Given this list of marker genes Ppara (NCBI Gene Id 399624), Nr5a1 (nuclear receptor subfamily 5, group A, member 1), Rorb, Thra, Thrb, Nr2f1, Rarb, Nr1d1, Paqr7, Or51e2 (NCBI Gene Id 70818), Nr2e3, Nr5a2, Nr1h4, Esr1, Pde3a, Vdr, Nkx3-1, Rara, Esrrb, Ahr, Nr1d2, Nr2e1, Esrra, Arnt, Rorc, Abhd2 (abhydrolase domain containing 2), Nr2c2, Hnf4a, Pgr, Nr1h5, Rora, Nr1i3 (NCBI Gene Id 98393), Ar, Nr1i2, Rxra, Nr6a1, Stat3, Esr2, Nr1h2 (NCBI Gene Id 381996), Rarg, Nr3c2, Hnf4g, Nr4a1, Esrrg, Pparg, Nr2c1, Nr2f6, Srebf1, Bach1, Nr4a2, Pou5f1, Nr1h3, Nr4a3, Paqr8, Nr2f2, Ahrr, Rxrg, Ppard, Rxrb, Gper1, Nr3c1, here is a description of the gene set: Mouse Gene Set: GOMF_LIGAND_MODULATED_TRANSCRIPTION_FACTOR_ACTIVITY studied in species Mus musculus A DNA-binding transcription factor activity regulated by binding to a ligand and that modulates the transcription of specific genes and gene sets. Examples include the lac and trp repressors in E.coli and steroid hormone receptors.